Given this list of marker genes BMP6, GPR35, SEMA4D, PKHD1, TCF4, DZIP1L, MST1, HFE, here is a description of the gene set: Cholangiocarcinoma Human Gene Set: HP_CHOLANGIOCARCINOMA studied in species Homo sapiens Cholangiocarcinoma is a primary cancer originating in the biliary epithelium i.e., the cholangiocytes, of the extrahepatic and intrahepatic biliary ducts. It is extremely invasive, develops rapidly, often metastasizes, and has a very poor prognosis. They are slow growing tumors which spread longitudinally along the bile ducts with neural, perineural and subepithelial extension.